The following is a description of a gene set: Genes predicted to be targets of miRBase v22 microRNA hsa-miR-5571-5p in miRDB v6.0 with MirTarget v4 prediction scores > 80 (high confidence targets). from publication Chen Y, Wang X (PMID 31504780) Human Gene Set: MIR5571_5P species: Homo sapiens, and this is the list of marker genes: DTWD2, ADGRL3, TOPORS, ID4, FYCO1, GPATCH2, HSF5, FZD3, MAGEA12, TMTC1, GPR158, ZNF506, CAMTA1, MDM1, SLC7A11, E2F6, ENPEP, MYZAP, ANKRD12, EIF4E, ZC3H4, THSD7A, MIER3, KDM7A, SLC19A3, RPF2, CELF2 (CUGBP Elav-like family member 2), SCN8A, TMEM117, GAD1, CLN5, CCDC126, SMARCE1 (SWI/SNF related, matrix associated, actin dependent regulator of chromatin, subfamily e, member 1), ARID4A, ADCY1 (adenylate cyclase 1), GABRA4, NFAT5, CNTLN, ZKSCAN8, PRDM15, MYSM1, TIPRL, ABI1, G3BP2, ELN, MEGF10, LDB2, ANKRD28, HOMER1, NUDT13, MDM2, ALDOB, HIPK1, CAV2, KIF5B, ETV1, SNAP23, BCDIN3D, CADM2, VPS37B, FLRT2, NOVA1, APBB2, IKZF2, MAGI3, SAXO1, RPGRIP1L, TMEM11, PPP3CB, ACTR3B, DDHD2, EPB41L2, DIP2B, LGMN, HCN1 (hyperpolarization activated cyclic nucleotide gated potassium channel 1), TRIB3, MZT1, DYNLT3, PARP11, DPP10, VSTM2A, SULT1C3, ACTN4, DOCK8, MIB1, GNAI1, ZNF90, PI15, COA5, MAPK1, RNF138, CCDC191, CRELD1, BMP2 (bone morphogenetic protein 2), SFRP4, SH3YL1, UBE2K, ASTN1, MDGA2 (NCBI Gene Id 161357), SLC34A2, FMN1, SLC41A1, ITGAV, IMPACT, STAP1, MED28, ZDHHC6, ERAP2, CFL2, IL17RD, CD226, INTS2, STT3B, PTPDC1, SP100, PRRC2C, PLEKHG2, TEKTL1, ARHGAP28, RORB, LRP6, NADK2, TSC22D1, GPRIN3, PSD3, KPNA1, STK32C, TSPAN2, PPP1R2, ZNF480, KLRD1, SHTN1, MRPL30, YTHDF2, MAP7, RSPH3, GRIP1, CALHM4, KLRF1, SLC5A12, SRSF6 (NCBI Gene Id 6431), WEE2, KLHL14, SLCO6A1, SUZ12, GPRASP3, PAN3, ATRN, RGN, WDR26, MIPOL1, PTMA, PDS5A, NR2F1, RAD51AP1, ACBD3 (NCBI Gene Id 64746), FOXP2, DHX8